The following is a description of a gene set: studied in species Homo sapiens Genes having at least one occurrence of the motif GCATAAWTTAT in the regions spanning 4 kb centered on their transcription starting sites. This matches the POU6F1 transcription factor binding site V$POU6F1_01 (v7.4 TRANSFAC). Human Gene Set: POU6F1_01, and this is the list of marker genes: HIP1R, KCNMA1, ELAVL2, RORA, ZFPM2, ZMAT4, FBXW7, EMC6, LIPG, GMPR, TRAM1, SEPHS1, STAG2, FBXO32, DLG2, MEIS1, SOX5, RFX3, ADAM11, WWP2, SOX14, PANK4 (NCBI Gene Id 55229), EPC2, EPHB2, GRIN2B, EMX2, TOB1, PCMTD1, S100PBP, COL1A2, EYA1, MPPED2 (metallophosphoesterase domain containing 2), IKZF2, USP11 (ubiquitin specific peptidase 11), MYH4, CCR3, LRTM1 (leucine rich repeats and transmembrane domains 1), HOXA9, FOXP2, BAZ1A, TMEM179, ZBTB20, DTNA, SKIL, BEGAIN, TLCD3B, ZNF827, DRG1, TP53TG5, FYN, NEUROG1, ETV5, HMGN2, MYT1, HOXC4 (homeobox C4), SUCNR1, ETV1, NDP, FGF13, SOX4, HOXA2, PDZRN4, PRPS1L1, ASCL4, NFRKB, GRIK3, PITX2, PRICKLE2, C5, HORMAD2, CXXC5 (NCBI Gene Id 51523), JPT2, NR2F1, KLRG1, FSTL1, NDUFAF3, MYOG, STOML2, CRH, SEPTIN4, GTF2IRD1, GPR183, POU4F1, SPAG9, KLHL41, PRIMA1, CNTLN, IPO4, EN1, RTP1 (receptor transporter protein 1), GNB1L, NR6A1, NEK6, CALCR (NCBI Gene Id 799), SLC12A8, GRIN2A, TRIM42, HOXA11, CILK1, FABP4, RADX, RTL10, CNTN6, POLR3C, SLC25A51, TGIF1, LRMDA, CADM1, ENSG00000291228, FABP2, OTUD7B, TMOD4, RHOBTB1, CASQ2, C12orf57, TENT5D, FOXP1, CREB5, TMEM88, RTL3, NTNG2, OFCC1, KRT28, GTPBP1, COL25A1, LINC01164, NSD1, INPPL1, HOXA5, CYFIP2, MARCKS, ZBTB18, RNF115, CAMK2D, CXCL13, HOXB4, ADCYAP1, CDH20, GRIK4, CFL2, COMMD10, SLC22A8, LMO3, CSRNP3, DTX3, FAM91A1, JOSD1 (NCBI Gene Id 9929), PCDH18, ZNF385B, PCTP, ARB2A, PCDH7, TEX11, ABLIM2, TAX1BP3, EFEMP1, PPP1R3A, OLFML3, PHOX2B, NGF, PRDM13, ABLIM1, STK32C, PTF1A, FEZF2, PCDHA3, TSPAN2 (tetraspanin 2), FOXN3, HOXA7 (NCBI Gene Id 3204), GRPR, KRT10, CASZ1, ERN1, NTF3, ID2, SHKBP1, CACNA2D3, RTN4, HOXD4, RERE, ZFHX3, WARS2, FHL5, HOXB6, CBLN1, CHD2, NCAM1, BNC2, MYH8, GPR3, HS3ST1, CELF2, MGAT4C, DLX1, TNFSF13B, TRAF3 (TNF receptor associated factor 3), TENM1, VGLL3, PLAG1, CTSK, CHCHD7 (coiled-coil-helix-coiled-coil-helix domain containing 7), CDAN1, DUSP1 (NCBI Gene Id 1843), MEIS2, POU2F1, IL1RAPL1, CBX6, MBNL1, TMIE, SOBP, GRB7, PTH1R, SYNPR, KCTD15, TSPAN9, PAQR9, STAU1, PPM1L, SP6, RBFOX2, OTX2, SYT5, SCG2, TLL1, C14orf39, RBMS1, CUX1, CACNA1C (NCBI Gene Id 775), PALS2, RTN4RL1, ERG, TFAP2D, TMEM178A, CNMD, HOXC5, PPARGC1A, LRRN4CL, RILP (Rab interacting lysosomal protein), LRRC15, HOXC6